The following is a description of a gene set: part of: Toll-like Receptor Cascades Reactome Pathway: Toll Like Receptor 9 (TLR9) Cascade This event has been computationally inferred from an event that has been demonstrated in another species.<p>The inference is based on the homology mapping from PANTHER. Briefly, reactions for which all involved PhysicalEntities (in input, output and catalyst) have a mapped orthologue/paralogue (for complexes at least 75% of components must have a mapping) are inferred to the other species. electronically inferred by orthology from the curated human pathway studied in species Mus musculus, and this is the list of marker genes: Mapk11, Pik3c3, Mapk3, Ppp2r1b, Cul1, Ube2n, Cd14, Tifa, Map3k8, Jun, Mapk7, Mapk14, Nfkbib, Rbsn, Irf5, Tab3, Dusp6, Rps27a, Nkiras1, Tlr4, Ticam2, Casp8, Tlr9, Nfkbia, Tab2, Map2k6, Ecsit, Mapk8 (NCBI Gene Id 26419), Peli2, Ly96, Tasl, Hmgb1, Lrrc14, Ikbkb, Nfkb1 (NCBI Gene Id 18033), Ppp2r5d, Map2k4, Nlrx1, S100b, Dusp7, Nlrc5 (NLR family, CARD domain containing 5), Rps6ka5, Ager, Irak1, Ubb, Map2k3, Irf7 (interferon regulatory factor 7), Rela, Nfkb2, Fos (NCBI Gene Id 14281), Mapk9, Vrk3, Tab1, Map2k7, Ube2v1